The following is a description of a gene set: species: Mus musculus Genes co-regulated in uterus during a time course response to progesterone: SOM cluster 1. from publication Yao MW, Lim H, Schust DJ, Choe SE, Farago A, Ding Y, Michaud S, Church GM, Maas RL (PMID 12554760) Human infertility and recurrent pregnancy loss caused by implantation defects are poorly understood. Hoxa-10-deficient female mice have severe infertility and recurrent pregnancy loss due to defective uterine implantation. Gene expression profiling experiments reveal that Hoxa-10 is an important regulator of two critical events in implantation: stromal cell proliferation and local immunosuppression. At the time of implantation, Hoxa-10 mediates the progesterone-stimulated proliferation of uterine stromal cells. Hoxa-10 mutants express a stromal cell proliferation defect that is accompanied by quantitative or spatial alterations in the expression of two cyclin-dependent kinase inhibitor genes, p57 and p15. Hoxa-10 deficiency also leads to a severe local immunological disturbance, characterized by a polyclonal proliferation of T cells, that occurs in place of the normal progesterone-mediated immunosuppression in the periimplantation uterus. Mouse Gene Set: YAO_TEMPORAL_RESPONSE_TO_PROGESTERONE_CLUSTER_1, and this is the list of marker genes: Lepr, Cebpb, Napsa, Igfbp3, Bcl2l11, Txnip (thioredoxin interacting protein), Spsb1 (NCBI Gene Id 74779), Kcnk2, Cxcl14, Tcf25, Ampd3, Hspa2, Aldh1a1, Cfhr4, Mcm5, Inmt, Bcl6, Tgfbi, Bmp4, Ltbp1, C1qtnf3, Itpr2, Bhlhe40, Xrn1, Id3, Pdk4, Klf9, Adamdec1, Mitf, Ro60, Klk1b16, Klk1b9, Irs2, Cited2, Map3k8, Ccn3, Klk1b26, Cmc4, Hp (NCBI Gene Id 15439), Gadd45b, Foxo3, Ddx6, Wnk1, Tns2, Igf1r, Chd8, Lrp6, Ddit3, Sat1, Net1, Gadd45g, Xist, Dusp1 (dual specificity phosphatase 1), Tfcp2l1, Msc, Nr4a1, Peg3, Acss1, Krt7, Gdpd3, Klk1, Entpd5, Akap8l, Cfhr1, Tnxb, Ndrg1, Fam20c, Per2, Parm1, Zscan26, Mycn, Nbl1